Given this list of marker genes ASXL1, CYP26C1, SRSF2, CBL, RUNX1, KIT, LYST, TET2, here is a description of the gene set: Any structural anomaly of mast cells, which are found in almost all tissues and contain numerous basophilic granules and are capable of releasing large amounts of histamine and heparin upon activation. studied in species Homo sapiens Human Gene Set: HP_ABNORMAL_MAST_CELL_MORPHOLOGY Abnormal mast cell morphology